Given this list of marker genes Gria3, Exosc9, Pakap (NCBI Gene Id 97198), Hif1a, Csmd1, Rflnb, Cd86, Zfp597, Sostdc1, Csnk1a1, Gtf2h1, Rock2, F12, Nfia, Rspo2, Utp15, Erbb4, Tmem231, Kitl, Ro60, Macrod2, Gipc1, Tcerg1, Gpr173, Drd5, Dock5, Tmed8, Gcn1, Igf2bp3 (insulin-like growth factor 2 mRNA binding protein 3), Lifr, Zfp423, Mybpc1, Ankrd7, Dpysl5, Isg20, Ube2j1, Gphn, Cbx2, Adam22, Dlx1, Ptk2b (NCBI Gene Id 211703), Sybu, Sestd1, Atoh1, Slc4a10, Psd3, Nsd1, Ncoa2, Ncor1, Htr1f, Slc25a36, Cert1 (NCBI Gene Id 77681), Tle1, Yae1d1, Gigyf2, Taf1b, Yif1a, Trpc5, Zfp410, Plaur, M6pr, Pou3f2, Zmat3, Unc80, Tdrd12, Tmem106a, Tmem215, Mpeg1, Spc24, Meox2, Sub1, Rnf126, Slain1, Itch, Fam168a, Hipk1, Nkrf, Pcdh10, Uchl5, Il22ra2, Cd28, Slitrk2, Synpo2l, Miga1, Olig1, Pom121, Abca5, Bcap29, Nsmce3, Tbl1xr1, Zfp950, Faf2, Insl5, Tcf12, Wdfy3, Rapgef6, 1700025G04Rik (RIKEN cDNA 1700025G04 gene), Gls, Defb30, Zrsr2 (NCBI Gene Id 97588), Lmod1, Hapln1, Mef2a, Scp2, Vxn, Timd6, Pan3, Dpp8, Adat1, Dnajc16, Fbxw4, Sele, Six6, Trim2, Gfpt2, Elavl4, Ikzf2, Tcea1, Dclk1, Gtf3c3, Col6a3, Irx2, Sptssb, Ubn2, Cnr1, Zbtb34, Pcm1, Tardbp, Bmpr2, Cyp2a22, Myef2, Ammecr1, Cilk1, Inpp4b, Kcnb2, Epc1 (enhancer of polycomb homolog 1), Armcx6, Eif3j2, Rbbp5, Mllt10, Hecw2, Cox14, D430041D05Rik, Crispld1, Mosmo, Krt42, Nfkb1, Adam12 (ADAM metallopeptidase domain 12), Bbof1, Tmem196, Trim58, Cflar, Saal1, Plin5, Maml1, Myo10, Septin12 (NCBI Gene Id 75648), Fntb, Abhd17c (abhydrolase domain containing 17C), Gnal, Nlrp10, Fgfr1, Car8, Foxj2, Mtdh, Ccnd3, Pdgfd, Otud6b, Mat2a, Fam83d, Psmc6, Frk, Eif3j1, Diras2, Gabra2, Ppp1r9a, Trip12, Gna13, Jph1, Myo5b, Slc39a6 (NCBI Gene Id 106957), Rbm12, Dnal1, Usp45, Armc2, Sall1, Ndnf, Bmi1, Slc27a6, Pphln1, Ptprm (protein tyrosine phosphatase receptor type M), Tcf4, Ltn1, Bach1, Rai2, Srpra, Slc24a2, Saxo2, Lrp8, Klk11, Zfp148, Cmpk1, Kif1b, Jade1, Grm5, Bet1, Hmgb1, Zdhhc21, Abhd2, Fsd1l, Ankrd40, Kctd8, Tjp1, Sf3b3, Sumf1, Nipal1, Bmt2, Srsf1, Trpv1, Ereg, Atp2b1, Glrx, Tex2, Trps1, Syt5, Tpd52l2, Ebf2, Ube2v1, Esp5, Creb1, Slc5a3 (solute carrier family 5 (inositol transporters), member 3), Pja1, Sin3a, Prkg1, Zfp462, Tanc2, Etv5, Ddx6, Trappc8, Ubl3, Cdh3, Bbx, Kif3c, Tgm4, Rab8b, Rap2a, Itm2c, Iqch, Txndc17, Spred1, Eloa, Ttc33, Gnptab, here is a description of the gene set: from publication Chen Y, Wang X (PMID 31504780) Genes predicted to be targets of miRBase v22 microRNA mmu_miR_6240 in miRDB v6.0 with MirTarget v4 prediction scores > 80 (high confidence targets). species: Mus musculus Mouse Gene Set: MIR_6240